Given this list of marker genes NAPSA, CD83, PSAT1, HOOK1, ERMN, BST2, TPD52, NCAPG2, SUV39H1, TNFRSF9, EGR2, ZNF518B, MMD, EXO1, CRMP1 (NCBI Gene Id 1400), MYB, BCAP29, NANP, ID3 (NCBI Gene Id 3399), MIX23, ST6GAL1 (NCBI Gene Id 6480), ADK, CMSS1, OPTN, CELF2, UMPS, NRGN, STAU2, SLC25A13, CBX6, CPT1A, ART3, FILIP1, SPOCK2, RBMXL1, INPP4B, SPAG5, DDIT4, CDK2AP1, SYNPO, FCER1G, MYC, HMGN3, FABP5, EIF1AX, ST14, LAG3, CEP128, UHRF1, CTLA4, RTP4, CCNB2, CHEK1, SGO1, MBOAT7, RAD18, IL21, NOP58, TACC2, KIF4A, ITM2A, PAQR4, CD244, RCSD1, XCL1, SRFBP1, NAA50 (NCBI Gene Id 80218), HELLS, FKBP5, CDC14A, VAMP5, DYNLT3, FRMD4A, CTPS1, C1QBP, SET, FIGNL1, PLK4, RAD54L, CCR9, CASP3, PWP1, CDK6, SNX9, MEMO1, KIF22, GNL3, GLDC, CDC6, SLC6A13, SMYD2, ATAD5, CD160, PDCD1, PLOD2, RNASEH2B, CORO2A, PSPC1, GMPS, DIAPH3, IFITM3, TAMM41, CD81, CXCL10, IRF8, MIS18BP1, CD109, BUB1, TOX, FANCD2, HSPA9, NDRG1, PSMD12, PSMC3IP (NCBI Gene Id 51769), HSH2D, PEX11A, CHST2, DUSP4, LPGAT1, STARD3NL, SLC37A2, DTL, SPC25, KNSTRN, BCAT1, AIM2, PTGER2, TFRC, ZAN, MAD2L1, XRCC2, UBASH3B, CKAP2, PCGF5, SEMA4C, FLNB, FEN1, TFDP1, MELK, SERPINE2, HAT1 (NCBI Gene Id 8520), GAS2, TFDP2, TOX2, PCTP (NCBI Gene Id 94001), PALS2, RAD51, LITAF, EHD4, TARS3, CENPP, CENPK, SPATS2, IPP, KIFAP3, SHCBP1, RNF128, PHLPP1, GCSH, RFC4, OXSR1, C15orf39 (NCBI Gene Id 56905), RGS10, NCF1, UTP6, AKR1E2, TBC1D31, C9orf152, MYO1E, MEF2C, ARHGAP11A, KPNA2, GCA, MTHFD2, CDC27, BLM, LAP3, CCNA2, NEK2, UCHL5, BMI1, ETV5, RSAD2, SMCO4, JAZF1, C12orf75, TRIP13, FAM81A, HMGB3, FAXC, SKAP2, RANBP1, SYPL1, GCNT1, TXNDC12, TIMM8A, CBLB, DUT, MAP2, BCL3, here is a description of the gene set: species: Homo sapiens Genes down-regulated in comparison of splenic primary CD8 effector T cells at day 8 post-acute infection versus splenic primary CD8 effector T cells at day 8 post-chronic infection. Understanding the response of memory CD8 T cells to persistent antigen re-stimulation and the role of CD4 T cell help is critical to the design of successful vaccines for chronic diseases. However, studies comparing the protective abilities and qualities of memory and naïve cells have been mostly performed in acute infections, and little is known about their roles during chronic infections. Herein, we show that memory cells dominate over naïve cells and are protective when present in large enough numbers to quickly reduce infection. In contrast, when infection is not rapidly reduced, memory cells are quickly lost, unlike naïve cells. This loss of memory cells is due to (i) an early block in cell proliferation, (ii) selective regulation by the inhibitory receptor 2B4, and (iii) increased reliance on CD4 T cell help. These findings have important implications towards the design of T cell vaccines against chronic infections and tumors. from publication West EE, Youngblood B, Tan WG, Jin HT, Araki K, Alexe G, Konieczny BT, Calpe S, Freeman GJ, Terhorst C, Haining WN, Ahmed R (PMID 21856186) Human Gene Set: GSE30962_ACUTE_VS_CHRONIC_LCMV_PRIMARY_INF_CD8_TCELL_DN